Given this list of marker genes OAS1 (2'-5'-oligoadenylate synthetase 1), NMNAT1, TBC1D15, DPT, CYTH3 (NCBI Gene Id 9265), RNASET2, NDST2, WASHC1, IMPDH1, MTHFR, XRCC6, ATP1B3, HTRA2, GADD45B, PI4K2A, LYZL1, NMT2, MTMR14, HSPA5, VAMP3 (NCBI Gene Id 9341), NCMAP, ANKRA2, SLC35G6, G6PC2, MITF, ARPP19, OVOL2, DNAJA2 (NCBI Gene Id 9237), PDGFRB, DEXI, SCHIP1, CROT, ATP10A, RMDN3 (NCBI Gene Id 55177), NTS, PTPRA, SEC24B, CTSC, BMI1, STX2, CYP2A6, SVBP, CDC27, CRIM1, G3BP2, MBIP, IL15, GPHN, CAPN10, SNX16, F10, GCAT, FNDC3A, MRPS6, CLDN18, ARF4 (ADP ribosylation factor 4), FCRLA, PNRC1, NINJ1, PLEKHO2, DNAJC7, CHAC2, PSME2, CAND1, NAT2, TPX2, TIPARP, IGBP1, REEP3, COLQ, C8orf33, LCP1, DNAJA1, TLR3, GNA13, MTHFS, CH25H, SLC29A3 (solute carrier family 29 member 3), ENDOD1, ADRA1A, NUDT9, CASK, NME7, TTC36, PTGES2, MCCC2, PCP4, DPCD, RRAS2, IRF4, CNTRL, PDK3, POMP, SYT17, PARP3, ITGAV, TOMM70, TLR6, NPY4R, CDC42EP4, ANXA2, GNG11, OLFM1, TCEANC2, HS6ST3, RND3, LAD1, E2F5, DNAJB1, GLA, KARS1, STAT3, LMO1, CHRNA3, UBE2B, PLEKHF2, CHPF, TRAPPC4, BBS2, KATNA1, CFAP298, TMEM140, IFIH1, IFT81, AEBP2, UPP1, SSBP3, RAB22A, IL2RA, RASAL1, PSMB9, PCM1, SIK1, TANC1, FOXP1, YPEL1, USP21, MBD3L1, FST, MCM10, TAPBPL, IRF8, LANCL2, ADPRM, FBXO25, HMGN5, WWOX, FURIN, QPRT, LHX6, UFM1 (ubiquitin fold modifier 1), RFX5, KLRK1, WRAP73, CCL24, WDR43, SP6, HLA-B, POLR2G, RAB12, RFK, LPAR1, UBR7, SPIC, EDA, PIAS2, CACNG2, RABGEF1, TSPAN5, RNPEPL1, ANKIB1, DDR2, GTF2B, NUDT19, TMEM70, SLAMF8, CDKN1B (cyclin dependent kinase inhibitor 1B), SLC22A13, RUNX2, RAD51, SUV39H1, HTRA1, HDAC1, GTPBP4, ANXA11, IFNA1, RNF14, ELOC, IRF1, VRK2, PHOSPHO1, MPP2, HSPB8, PLEKHS1, PSME4, ASB13, PDZD11, DAB2, PI4K2B, MPP1, here is a description of the gene set: Human Gene Set: GSE17721_LPS_VS_GARDIQUIMOD_8H_BMDC_UP Genes up-regulated in comparison of dendritic cells (DC) stimulated with LPS (TLR4 agonist) at 8 h versus DC cells stimulated with Gardiquimod (TLR7 agonist) at 8 h. studied in species Homo sapiens mouse primary BMDCs were stimulated with tlr ligands and gene expression changes were profiled on Affymetrix arrays from publication Amit I, Garber M, Chevrier N, Leite AP, Donner Y, Eisenhaure T, Guttman M, Grenier JK, Li W, Zuk O, Schubert LA, Birditt B, Shay T, Goren A, Zhang X, Smith Z, Deering R, McDonald RC, Cabili M, Bernstein BE, Rinn JL, Meissner A, Root DE, Hacohen N, Regev A (PMID 19729616)